The following is a description of a gene set: A series of reactions, mediated by the intracellular serine/threonine kinase protein kinase C, which occurs as a result of a single trigger reaction or compound. Human Gene Set: GOBP_PROTEIN_KINASE_C_SIGNALING studied in species Homo sapiens, and this is the list of marker genes: PRKCB, AKAP12, EGFR, PRKCD, HSPB1, CD40, DGKQ, PRKCA, SLC26A6